Given this list of marker genes KRT18, CNPY2, CAMKK2, MCCC2 (methylcrotonyl-CoA carboxylase subunit 2), RAB11A, ATP6V1G1, SOX4, CANX, DAPK1, SLC25A6, PARG, HSD17B4, MANF, AMACR, EEF2, GUCY1A1 (NCBI Gene Id 2982), PPIB, ERG, SEC16A, UGDH, CACNA1D, GUSB, BDH1, CXADR, TRIM27, EIF4A1, PDLIM5, F2R, DKC1, NACA, BICD1, UAP1, PAICS, ZNF217, RPL31, ZNF652, MYO6, RACK1, SND1, MBOAT2, here is a description of the gene set: Genes up-regulated in prostate cancer vs benign prostate tissue, based on a meta-analysis of five gene expression profiling studies. Despite efforts to profile prostate cancer, the genetic alterations and biological processes that correlate with the observed histological progression are unclear. Using laser-capture microdissection to isolate 101 cell populations, we have profiled prostate cancer progression from benign epithelium to metastatic disease. By analyzing expression signatures in the context of over 14,000 'molecular concepts', or sets of biologically connected genes, we generated an integrative model of progression. Molecular concepts that demarcate critical transitions in progression include protein biosynthesis, E26 transformation-specific (ETS) family transcriptional targets, androgen signaling and cell proliferation. Of note, relative to low-grade prostate cancer (Gleason pattern 3), high-grade cancer (Gleason pattern 4) shows an attenuated androgen signaling signature, similar to metastatic prostate cancer, which may reflect dedifferentiation and explain the clinical association of grade with prognosis. Taken together, these data show that analyzing gene expression signatures in the context of a compendium of molecular concepts is useful in understanding cancer biology. Human Gene Set: TOMLINS_PROSTATE_CANCER_UP from publication Tomlins SA, Mehra R, Rhodes DR, Cao X, Wang L, Dhanasekaran SM, Kalyana-Sundaram S, Wei JT, Rubin MA, Pienta KJ, Shah RB, Chinnaiyan AM (PMID 17173048) species: Homo sapiens